The following is a description of a gene set: Genes down-regulated in comparison of mast cells versus neutrophils. species: Homo sapiens from publication Jeffrey KL, Brummer T, Rolph MS, Liu SM, Callejas NA, Grumont RJ, Gillieron C, Mackay F, Grey S, Camps M, Rommel C, Gerondakis SD, Mackay CR (PMID 16474395) Human Gene Set: GSE3982_MAST_CELL_VS_NEUTROPHIL_DN In the present study we used Affymetrix oligonucleotide microarrays to produce gene transcription profiles for the major leukocyte types in humans. This comprehensive dataset enabled us to not only establish which genes were expressed in each leukocyte type, but also which genes were expressed in each subset after activation. The used of a comprehensive dataset of gene profiles from all the major human leukocyte subsets enabled a novel and powerful means for identification of genes associated with single leukocyte subsets, or different immune paradigms., and this is the list of marker genes: HEXIM1, NEDD9, BAZ1A, TNFAIP3, TKT, SYNE2, TRANK1, SH2D3A, STAT3, SLC25A28, CYTH4, KCNA6, ZEB1, ADAM11, AQP3, FMO1, SERINC1, HERC3, MAP2K4, CSAD, KIR2DL4, MARF1, LEP, CSRP2, GPR162 (NCBI Gene Id 553113), IFIH1, ADAM15, NECTIN3, LARP6, PRR7, CCNJL, CABIN1, KCNK7, ZNF586, CYP4F11, RLF, PIM2, VCPIP1, HTR2A, TNRC6B, NCF4, LSM14A, CD14, SPINT1, NRDC, APOLD1 (NCBI Gene Id 81575), IP6K1, SH2B2, LINC00472, AZGP1, DLK2, MLF2, LIMK2, LSP1, GPR87, ERF, TMC5, MARK3, CDKN2D, ELL, JMJD1C, ZNF200, LMNB1, SELPLG, NPR3, LTBR, TCL1A, ARAP1, SMCP, ISG20, MINDY1, JUNB, OPHN1, SLC31A2, RNF44, LILRA6, TYROBP (NCBI Gene Id 7305), ARAP3, OR12D2, MC4R, IPCEF1, SGTA, BMX, ZNF165 (NCBI Gene Id 7718), H3C2, SLC17A2, IFI16, RAB35, BCL6, GLRX, CXCL14, DHTKD1, APAF1, HNRNPH2, ABCD1, ZNF407, PRCP, SLC15A3, MED15 (mediator complex subunit 15), PSG4, MON1B, RAB36, GRIA2, KCNA3, S1PR4, EVI2A (ecotropic viral integration site 2A), NIBAN1, KLHL25, PSAP, USP4, PFKFB3, PSMB9, SYCP2, KAT2B, GK, GSTA3, HOOK1, SEMA6A, SLK, FOLH1B, SPI1, LRRFIP1, CCZ1, MIR22HG (NCBI Gene Id 84981), GMIP, OXT, ADIPOR1, MX2, SPAG9, DAZAP2, SCAF11, HDAC9, DGAT1, CCN2, PSD3, BIRC7, SLC11A1, TRIM8, DOCK5, INS, TLR6, GIT2, VASP, GNAQ, RAD9A, ACSL1, PISD, CHRD, FBXO42, CDC42EP2, ACOX1, MMP25, PIM1, TBC1D15, CTDSP2, JADE1, RRP12, DENND5A, TSPAN32, IFITM1, BLTP3B, CADM4, CX3CR1, CEACAM3, MED25, ASAP1, SH2D3C, LGI2, SAMD9, BTN3A1, C5AR1, AGMAT (agmatinase (putative)), KRTAP2-4, INPP4A, BMAL1, DNAJC4, SOX10, KDM5C, RAB40C, PPIG, TAGLN3, VPS37B, PPIL6, EFHD2, IKBKG, WAS, SLC12A6, XKR8, FLOT1, MTARC1, ETV7, MBP, SLC12A9, AOX1, F2RL1, FBXO22, PTAFR